The following is a description of a gene set: The gene expression program underlying the specification of human cell types is of fundamental interest. The study authors generated human cell atlases of gene expression and chromatin accessibility in fetal tissues. For gene expression, the study authors applied three-level combinatorial indexing to >110 samples representing 15 organs, ultimately profiling ~4 million single cells. The study authors leveraged the literature and other atlases to identify and annotate hundreds of cell types and subtypes, both within and across tissues. Our analyses focused on organ-specific specializations of broadly distributed cell types (such as blood, endothelial, and epithelial), sites of fetal erythropoiesis (which notably included the adrenal gland), and integration with mouse developmental atlases (such as conserved specification of blood cells). These data represent a rich resource for the exploration of in vivo human gene expression in diverse tissues and cell types. studied in species Homo sapiens Marker genes curated from the annotated cluster as represented in the Descartes Human Gene Expression During Development database. from publication Cao J, O'Day DR, Pliner HA, Kingsley PD, Deng M, Daza RM, Zager MA, Aldinger KA, Blecher-Gonen R, Zhang F, Spielmann M, Palis J, Doherty D, Steemers FJ, Glass IA, Trapnell C, Shendure J (PMID 33184181) Human Gene Set: DESCARTES_FETAL_EYE_HORIZONTAL_CELLS, and this is the list of marker genes: TNR, ONECUT3, IL12A-AS1, ENSG00000259203, CACNG3, ONECUT2, PMFBP1, ANKK1, NDST3, ESRRB, LINC02740, TNR-IT1, ONECUT1, TMPRSS9, ARHGAP26-IT1, FRMPD4, LINC02842, MRPL37P1, DRD2, NTRK1, MEGF11